Given this list of marker genes PTPRG, SRSF1, PTPRD, LTN1, GALNT3, CISD2, ZC2HC1A, CALU, ELOVL2, CASR, MARCHF5, PPP2CB, PCM1, POLD3, NUTF2, LIN54, CDYL, ZEB1, MBNL3, TMTC3, ARMCX1, IL20, ASAP2, GPC6, CCL4L2, ADAM9, USP12, ANK2, CCDC152, PTPN14, SLC25A24, MOXD1, CNOT6L (CCR4-NOT transcription complex subunit 6 like), ARF4, EFR3A, SETX, DLEU7, PDC, ZBTB33 (NCBI Gene Id 10009), THAP6, AFF4, SELENOT, PDZRN3, CNTD1, TMED2, PPFIA2, STAR, FRMD4A, ATRX, RBBP8, PRRX1, UBE3C, TMEM106B, UBE2E1, UVRAG, MCL1, ARID2, SPATA18, BET1, TUBB2B, ATF7IP, WDPCP, TRMT10A, FZD5, MDGA2, TRIM33 (NCBI Gene Id 80027), GRB14, ZMYM2, KLHL24 (NCBI Gene Id 79965), MLF1, WAPL, MAP1B (microtubule associated protein 1B), TRMT9B, S100PBP, NCAM2, NR2C1, SRSF11, DMRTB1, TEX12, CPSF6, CCL4, PHLDA1, TBC1D12, SCN8A, ZNF311, TLR8, B4GALNT1, GREB1, UBE2D3, SP8 (NCBI Gene Id 378050), TIPRL, ADD3, TENT4B, RHOQ, BOLA2-SMG1P6, CEACAM7, EPHA3, FAM169A, VEZF1, SEMA3E, CACNB4, CADPS2, DDX3X, ETNK1, SLC35A5, PIK3C2A, here is a description of the gene set: from publication Chen Y, Wang X (PMID 31504780) Human Gene Set: MIR5583_5P species: Homo sapiens Genes predicted to be targets of miRBase v22 microRNA hsa-miR-5583-5p in miRDB v6.0 with MirTarget v4 prediction scores > 80 (high confidence targets).